The following is a description of a gene set: RUNX2 regulates expression of several genes implicated in cell migration during normal development and bone metastasis of breast cancer cells.<br>RUNX2 stimulates transcription of the ITGA5 gene, encoding Integrin alpha 5. Integrin alpha-5 promotes adhesion of breast cancer cells to the bone, thus facilitating formation of bone metastases. ITGA5 is implicated in migration of human dental pulp stem cells. In zebrafish, Integrin alpha-5 coordinates cell migration during development of sensory organs. During mouse retinal angiogenesis, Integrin alpha-5 regulates migration of endothelial cells.<br>The ITGBL1 gene encodes Integrin beta like protein 1, which is implicated in regulation of TGF-beta signaling and RUNX2-induced bone metastasis of breast cancer.<br>RUNX2 mediated transcription of the MMP13 gene, encoding Colagenase 3 (Matrix metalloproteinase 13), is stimulated by AKT mediated phosphorylation of RUNX2 and is implicated in invasiveness of breast cancer cells. MMP13 is involved in migration of innate immune system cells in response to injury and in remodelling of skeletal tissues.<br> Reactome Pathway: RUNX2 regulates genes involved in cell migration part of: Transcriptional regulation by RUNX2 species: Homo sapiens, and this is the list of marker genes: AKT2, ITGA5, MMP13, CBFB, ITGBL1, RUNX2, AKT3, AKT1